Given this list of marker genes Chd2, Lmln, Ints2, Fbxo22, Hnrnpf, Polg2, Slc35d2, Alyref2, Ighv1-62, Nras, here is a description of the gene set: Genes containing one or more binding sites for (Raly) in their promoter regions (TSS -1000,+100 bp) as identified by GTRD version 20.06 ChIP-seq harmonization. from publication Yevshin I, Sharipov R, Kolmykov S, Kondrakhin Y, Kolpakov F (PMID 30445619) studied in species Mus musculus Mouse Gene Set: RALY_TARGET_GENES